The following is a description of a gene set: from publication Bedogni F, Hevner RF (PMID 34321999) Genes expressed at higher levels in caudal regions of the cortical plate in embryonic day 14.5 mouse cortex. species: Mus musculus Mouse Gene Set: HEVNER_CORTEX_CAUDAL_CORTICAL_PLATE, and this is the list of marker genes: Pcsk2, Tenm3, Crtac1, Lhx9, Tgfbr1, Zfp521, Crabp1, Tenm2, Nefm, Cacna1g, Ncam2, Sv2b, Igfbp3, Chrna7, Mical2, Fosl2, Ngfr, Asic2, Nefl, Crym, Neo1, Cck, Ptprn, Hcn1, Six2, Cacna2d3, Cemip2, Nr4a3, Olfml2b, Vrk2